The following is a description of a gene set: Genes having at least one occurrence of the motif NNNRRCCAATSRGNNN in the regions spanning 4 kb centered on their transcription starting sites. This matches the transcription factor binding site V$NFY_01 (v7.4 TRANSFAC). Human Gene Set: NFY_01 studied in species Homo sapiens, and this is the list of marker genes: ELAC2, ATP2A2, LRATD1, DND1, ZMYND8, MACO1, H3-3B (NCBI Gene Id 3021), SERPINA6, WNT8B, RHOF, KIF23, NEUROG3, GRHL3, PASK, MRTFA, NPHP4, CCDC102A, COQ8A, GUCA2A, COA3, HK2, DLG3, ACTB, TREX1, KLF1, TMEM129, SGO2, MROH8, UFD1, CDV3, TLE4, FADS1, SLC20A1, NKX6-1, SYCP3 (NCBI Gene Id 50511), CHP1, CHAC1, PDGFRB, XPO1 (exportin 1), SREBF2, OARD1, UTP18, ODF2, MYOCD, ETV5, RNF5, PI4K2A, IER5, RPN2, DLX1, PDP1, CKS2, ACACA, COL5A3, ELMO1, MTMR14, HMGA2, DLEU2, CCDC140, NOL4, SLC25A35, JUNB, STMN1, ZNF436-AS1, COQ10B, SIX1, RAB5IF, CYP24A1, HIF1A, GSK3B, CDC25A, FIZ1, ZNF385A, PAN2, TDO2, ZMYM2, GRHL2, CCDC186, ACR, GLB1L2 (galactosidase beta 1 like 2), HOXB13, AGPAT1, TMA7, CLTA, LDB2, DPF3, DNAJB11, PCDH9, DLX3, KLF10, KLF11, MAZ, MOB1A, SORBS2, JARID2, CDC45, HDX, ABHD12, EHF, OLIG2, ZNF436, PPP2R5C, BCAT2, SRSF2, NCAM1, PCYT2, UBB (ubiquitin B), ISL1, UBXN11, NUBP2 (NCBI Gene Id 10101), MIS12 (NCBI Gene Id 79003), PRPF38B, NOP56, PLA2G3, PTCH2 (NCBI Gene Id 8643), TAF15, LIMD2 (NCBI Gene Id 80774), FRMD8, HNRNPR, PCF11, PPP2R1A, BAHD1, LRP8, FAM204A, GGNBP2, FDPS, NUMB, SHC3, GPC3 (glypican 3), PMEL, SIX2, GTF2I, CNN3, BARHL1, NARF, TSPAN13, CNTD1, PPP1R7, H2BC1, ELAVL4, PRDM5, CCDC51 (NCBI Gene Id 79714), TXNIP, CDK1, PCNT, GNAT1, DSTN, WBP2, ABCF2, MLEC, COL1A1, ERG28, PAX3, HOXC4, CDH6, PIK3R3, KCNJ2, SSBP3, TSC22D1, TAFA4, NUP98, ABCA7, ZBTB10, SLIT3, ARL17A, TM7SF2, LHX5, SC5D, SPTSSA, LHX1, CCNA1, INSM2 (INSM transcriptional repressor 2), HES1, ASB7, MYO1E, CDH1, HIGD1A, RHOB, SPDYA, HSPA1L, NPTX2, TSPAN33, SFRP1, ACTL6A, NFATC4, KBTBD8, HLA-DQB2, WNT3, C12orf57, ZFP36L2, CIT, SLC25A13, C21orf58, H2AC1, UBALD2, USP21, PNRC1, ING5, ZNF524, HSCB, TLX3, NUMBL, SMAD2, NEK2, SP140L, ABAT, ACYP1, AGFG2, HIVEP3, CALM2, GPR50, CAT, RGS3, SESN2, PPP1R1B, POU3F3, PPM1A, SOX2, HCP5, RACGAP1, LINS1, PDIA3, SLC25A27, M6PR, NANS, SLC43A2, KMT2E, FA2H, INTS7, PRCP, DCAF11, CYP39A1, MTERF2, MAEL, SLC26A9, GGCT, VCP, DDR2, DDX4, LRRC20, FUT8, GORAB, PDZD7, CATSPER2, ZFP91, SEPTIN4, DLEU1, FAM117B, FGF20, SELENOK, NKX6-2, DUSP6 (NCBI Gene Id 1848), TACC3, NFYA, WASF2, EXD1, PTF1A, HSPA1A, KLF9, KDM3A, PLK1